Given this list of marker genes ALDH6A1, GSTT1, EPHX2, ALDH1A1, PIK3R1, EPHX1, here is a description of the gene set: studied in species Homo sapiens Selected down-regulated MET target genes from a classifier of hepatocellular carcinoma (HCC) cases; associated with poor survival. from publication Kaposi-Novak P, Lee JS, Gòmez-Quiroz L, Coulouarn C, Factor VM, Thorgeirsson SS (PMID 16710476) Identification of specific gene expression signatures characteristic of oncogenic pathways is an important step toward molecular classification of human malignancies. Aberrant activation of the Met signaling pathway is frequently associated with tumor progression and metastasis. In this study, we defined the Met-dependent gene expression signature using global gene expression profiling of WT and Met-deficient primary mouse hepatocytes. Newly identified transcriptional targets of the Met pathway included genes involved in the regulation of oxidative stress responses as well as cell motility, cytoskeletal organization, and angiogenesis. To assess the importance of a Met-regulated gene expression signature, a comparative functional genomic approach was applied to 242 human hepatocellular carcinomas (HCCs) and 7 metastatic liver lesions. Cluster analysis revealed that a subset of human HCCs and all liver metastases shared the Met-induced expression signature. Furthermore, the presence of the Met signature showed significant correlation with increased vascular invasion rate and microvessel density as well as with decreased mean survival time of HCC patients. We conclude that the genetically defined gene expression signatures in combination with comparative functional genomics constitute an attractive paradigm for defining both the function of oncogenic pathways and the clinically relevant subgroups of human cancers. Human Gene Set: KAPOSI_LIVER_CANCER_MET_DN